The following is a description of a gene set: Telangiectasias refer to small dilated blood vessels located near the surface of the skin or mucous membranes, measuring between 0.5 and 1 millimeter in diameter. Telangiectasia are located especially on the tongue, lips, palate, fingers, face, conjunctiva, trunk, nail beds, and fingertips. studied in species Homo sapiens Human Gene Set: HP_TELANGIECTASIA Telangiectasia, and this is the list of marker genes: ARPC4 (actin related protein 2/3 complex subunit 4), RASA1, SMAD4, COL3A1, ELMO2, PDPN, TMC6, LIG4, SOX18, SEC23B, CYLD, PCNA, MT-ND6, ATRX, TALDO1, IRF5, SASH1, PIGW, LRP5, ERCC4, CCR6, POLH, PNKP (polynucleotide kinase 3'-phosphatase), ANTXR2, MT-ND1, GABRD, NOP10, SDHD, PIGL, NEU1, ATM, DPM1, PIGO, WRAP53, LIG1, LBR, MASP1, MT-ND4, RTEL1 (regulator of telomere elongation helicase 1), DIAPH1, CTC1, MT-ND2, KIT, PARN, PRDM16, VPS53, RECQL4, CTSA, PIGV, RNF168, NPM1, TTI1 (NCBI Gene Id 9675), MMP23B, MT-CO1, ACTA2, AKT1, MST1, GDF2, STXBP1, GNPTAB, COL7A1, POLE, WRN, UVSSA, IARS2, SDHB, XRCC4, SLC37A4, EPHB4, SEMA4D (semaphorin 4D), PRKCZ, RERE (arginine-glutamic acid dipeptide repeats), PEX6, ANAPC1, POLD1, STING1, ERCC3, SPEN, FZD4, LMNA, KIAA0319L, GNA11, TERT, KLLN, BLM, CTNNB1, UBE4B, DNAJC30, XPC, MT-CO3, SKI, ERCC2, TYMS, IL7, USF3, DDB2, TCF4, NDUFS2, MT-ATP6, NF1 (NCBI Gene Id 646021), GNAQ, WNT10A, FERMT1, BMPR2, USB1, CAV1, SDHC, ACVRL1, TSPAN12, PGAP2, ARX, GLA, XPA, LMX1B, TINF2, SLC29A3, STN1, FRG1, NDP, NBN, DKC1, PIK3CA, TREX1 (three prime repair exonuclease 1), SETX, PEPD, IKBKG, RNF213, PORCN, CASZ1, SETD2, KCNAB2, PTEN, PGAP3, ENG, CIB1, CCM2, ABCC6, GPR35, HFE, ERCC6 (ERCC excision repair 6, chromatin remodeling factor), ZNF408, MT-ND5, ARL6IP6, MRE11, ATR, TERC (telomerase RNA component), CAST, SLC2A10, PIGY, ERCC5, CCN2, MT-CYB, NAGA, NHP2, BMP2, HSPG2, MT-ND4L, TMC8, ENPP1, HLA-DRB1, LUZP1